The following is a description of a gene set: Human Gene Set: GOBP_REGULATION_OF_STORE_OPERATED_CALCIUM_CHANNEL_ACTIVITY Any process that modulates the frequency, rate or extent of store-operated calcium channel activity. studied in species Homo sapiens, and this is the list of marker genes: UBQLN1, CRACR2A, ASPH, STIMATE, STIM1, CASQ1, STIM2